The following is a description of a gene set: Mouse Gene Set: CUI_T_CELL_CD4_FGF_BASIC_RESPONSE_DN species: Mus musculus Cytokines mediate cell-cell communication in the immune system and represent important therapeutic targets. A myriad of studies have highlighted their central role in immune function, yet we lack a global view of the cellular responses of each immune cell type to each cytokine. To address this gap, the authors created the Immune Dictionary, a compendium of single-cell transcriptomic profiles of more than 17 immune cell types in response to each of 86 cytokines (>1,400 cytokine-cell type combinations) in mouse lymph nodes in vivo. A cytokine-centric view of the dictionary revealed that most cytokines induce highly cell-type-specific responses. For example, the inflammatory cytokine interleukin-1β induces distinct gene programmes in almost every cell type. A cell-type-centric view of the dictionary identified more than 66 cytokine-driven cellular polarization states across immune cell types, including previously uncharacterized states such as an interleukin-18-induced polyfunctional natural killer cell state. Genes negatively differentially expressed in cell type: CD4+ T cell upon treatment with cytokine: FGF-β in mouse lymph nodes in vivo. from publication Cui A, Huang T, Li S, Ma A, Pérez JL, Sander C, Keskin DB, Wu CJ, Fraenkel E, Hacohen N (PMID 38057668), and this is the list of marker genes: Klf6, Junb, Cd74, Hspa1b, Ppp1r15a, Fos, Hspa1a, Tsc22d3, Jun, Dusp2